Given this list of marker genes APBB1IP, IRF1, MTOR, HSD17B8, ITGA11, SMARCA1, LRRC69, RPS3A, DST, MANEAL, TMT1B, PRDM15, MICAL1, SRSF6, NFKBID, RPS6KA5, ADAMTS18, here is a description of the gene set: studied in species Homo sapiens from publication Chen Y, Wang X (PMID 31504780) Genes predicted to be targets of miRBase v22 microRNA hsa-miR-1292-5p in miRDB v6.0 with MirTarget v4 prediction scores > 80 (high confidence targets). Human Gene Set: MIR1292_5P